The following is a description of a gene set: Catalysis of the movement of phosphatidylethanolamine from the exoplasmic to the cytosolic leaflet of a membrane, using energy from the hydrolysis of ATP. studied in species Homo sapiens Human Gene Set: GOMF_PHOSPHATIDYLETHANOLAMINE_FLIPPASE_ACTIVITY, and this is the list of marker genes: ATP11C, ABCA4, ATP11A, ABCB1, ATP8A2